The following is a description of a gene set: species: Homo sapiens from publication Chen Y, Wang X (PMID 31504780) Genes predicted to be targets of miRBase v22 microRNA hsa-miR-487a-3p in miRDB v6.0 with MirTarget v4 prediction scores > 80 (high confidence targets). Human Gene Set: MIR487A_3P, and this is the list of marker genes: STIM2, ZEB2 (zinc finger E-box binding homeobox 2), LEKR1, RBM11, MGARP, MOB1B, NTF3, MTMR12, TNPO1, RPRD1A, CNKSR3, ZNF780A, NLK, MAGI2, BTG2, TXLNG, SNRNP40 (NCBI Gene Id 9410), SMAD7, CARNMT1, PLAC8, CAMSAP1, GLRB, ZNF281, KIAA1217, ZNF57 (zinc finger protein 57), TEAD1, USP34, TRIB2, CNR1, PPM1B, LRRCC1, PNPLA4, ATL3, LRRTM2, ZNF33A, TASOR2, STYX, YPEL4, ST6GAL2, SIRT1, TMEFF2, SP3, REPS2, RNF217, MTMR10, DCUN1D4, PDZD2, ADGRL2, TMEM67, CDH8, PON3, APPL1, CLEC12A, AGFG1, ADAMTS5, PPP4R4, TUT7, AZIN1, CBLB, LRCH1, CRBN, STXBP3, PPM1A, ZC3H7A, ZNF454, ZCCHC2, ASAP2, SEPTIN8, EVI5, RGS14, TMEM68, SNX2, ATF2, KIF1B, NUDCD2, ENY2, KCNMA1 (potassium calcium-activated channel subfamily M alpha 1), SNX6, PRKAA1, VTI1B, ATP11C, ANKRD50, COBL, ABTB2, RLN1, CHKA, ILRUN, GPM6A, SEMA3C, GRIA4, PDE4D, DYRK1A, PDE10A, NEK4, CALCOCO1, RP2, ATP8B1, ANKS1B, APLP2, CEP192, PUM2, ANXA4